The following is a description of a gene set: Any of a group of soluble proteins functioning in the activation of ribosome-mediated translation of mRNA into a polypeptide. species: Homo sapiens Human Gene Set: GOMF_TRANSLATION_ACTIVATOR_ACTIVITY, and this is the list of marker genes: ABCF1, DAZ2, MIF4GD, DHX29, DAZ4, RPS27L, CTIF, PABPC1 (poly(A) binding protein cytoplasmic 1), DAZ1, PAIP1, LARP1, DAZ3, DAZL, BOLL